The following is a description of a gene set: Any process that stops, prevents, or reduces the frequency, rate or extent of chemical reactions and pathways involving a protein. species: Homo sapiens Human Gene Set: GOBP_NEGATIVE_REGULATION_OF_PROTEIN_METABOLIC_PROCESS, and this is the list of marker genes: VBP1 (NCBI Gene Id 7411), MIR132, C9orf72, SIRT1, TP53, PRKCG, PRKAA2, MIR299, PBK, MAGEA3, TM4SF20, PAQR3, ATG14, GTPBP4, F8A1, STYX, MIR146A, UCHL5 (ubiquitin C-terminal hydrolase L5), MIR499A, PTPN3, AATF, EIF4A3, TMEM98, MARCHF7, DTX3L, AXIN1, MIR103A1, WTIP, JAK3, MAP1A, MAPK8IP1, PTPRJ, FGA (NCBI Gene Id 2243), OGT, PRR5L, MIR133B (NCBI Gene Id 442890), MIR106B, SERPINB13, CLN8, SQSTM1, SPON1, TIMP1, APCS (amyloid P component, serum), PSME3IP1, CDKN2A, MIR24-1, ITGAV, SOCS4, ZNF540, PFDN4, MAP3K20, CDK5RAP1, TREM2, MYCBP2, VPS35, RTN2, INSM1, MIR1271, CAMLG, CSTA, INHBB, MIR361, RNF139, ARRB1, PRNP, LAPTM4B, MIR346, MDM2, MIR214, ADIPOQ, DEPTOR, SERPINB3, SHMT1, MIR135B, GZMB, FETUB, IVNS1ABP, CTNNB1, HDAC6, NELL1, DCUN1D3, EIF4EBP3, INPP5F, SNX12, SAMD4A, MIR339, QKI, VPS25, ZC3H12A, EIF2AK3, CDYL, IBTK, MIR181C, MAD2L1, MIR1-1, MIR96, TYMS (thymidylate synthetase), APOD, TIMP4, ROCK1, GABARAPL2, AJUBA, YBX1, GSKIP, RPL11, XRN1, MAGEA2B, MIR141, SMAD3, PML, EIF4G1, DBNDD2, PSEN1, MIR874, AZIN1, ZFYVE28, SORL1, PTPRC, KNG1, MIR212, CAPRIN1, PHF20L1, ANG, RBM4, MTM1, EIF4EBP2, TRIM71, CYFIP1, SUFU, EGFR, MARCHF6-DT, RPS7, EFNA1, INS, RYBP, SERPINB8, PURA, GRIN2C, PARP14, MIR152, IGF1, NANOS2, ACOT8, TAF9, BTG2, SERPINE2, SAMD4B, MIR378A, HHEX, TTC36, TFAP4, TRIM40 (tripartite motif containing 40), SF3B3, SERPINB9, NANOS1, SRCIN1, BEX3, MEN1, GGA3, PAK2, GPRC5A, PTK6, SNX3, RASSF2, ATP13A2, PTPN2, FBXO5, ITGB1BP1, RELA, HMG20A, SH3RF2, SERPINE1, PTEN, APC, SERPINB12, PRKCA, MIR455, UFL1, LRIG2, RTN3, MIR100, MIR17, BEX4, ZAR1, WAC, BACE2, GBA1, EDNRB, YWHAG, EIF2AK4, STK38, ILF3, MIR200C, TSPO, F2, BAG5, TRIM27, FHIT, SNX6, MIR28, DNAJC3, CST4, IGF2BP3, VPS28, WFS1, CCAR2, MIR106A, ECM1, MIR365A, HSP90AB1, RGP1, ADARB1, PIN1, LYN, WT1, SENP2, PLAU, DEDD, SFRP2, CRB2, SOCS5, MIR26B, EIF4ENIF1, MIR503, MIR15B, ZFP36, PHB1, U2AF2, RIDA, MIR147A, PRKCE, GIPC1, SIRT4, FKBP8, PPP1R15B, MIR644A, ZNF598 (zinc finger protein 598, E3 ubiquitin ligase), CDKN1A, CDK5 (cyclin dependent kinase 5), MIR31, TRIM21, USP4, NOP53, USP17L2, SNCA, PSMF1, USP9X, MIR298, NMNAT2, N4BP1, IL1R2, UBE2B, EPPIN, CNOT1, DDX3X, SLIT2, MIR29A, GIGYF2, GAPDH, SERPINF2, MIR448, SPOCK3, DMTN, RGS2 (NCBI Gene Id 5997), RTN1, RPL23, RBM24, SVBP, PURB, CRTAP, CNOT10, RPS3, UNK, MRPL13, HMG20B, NQO1, DAPK1, MIR15A, NR1H3, MIR148A, WARS1, PPIA, IL10, CELF1, F8A3, HABP4, ITM2A, RPL5, ALKBH3, PINX1, LDLR, MIR659, WNT1, MIR134, NCL (NCBI Gene Id 4691), FLOT2, PFDN1, MIR520E, SIRT2, ACP4, CD84, GPS2, IRAK3, FBLN1, DAPK3, CNOT9, NLRP7, CNKSR3, PKIA (cAMP-dependent protein kinase inhibitor alpha), MAGEA2, GLG1, MINAR1, SHFL, PTX3, GRB7, AKT1S1, MIR10B, MIR29B1, PANO1, PDCL3, UBXN1 (NCBI Gene Id 92151), GADD45A, AIDA, TLK2, MIR153-1, NOS2, ATRAID, MGAT4D, CD300A, GNL3L, HFE, CEP43, EIF2S1, MIR19B1, MIRLET7A1, TNRC6C, PPM1E, MIR181A2, RECK (reversion inducing cysteine rich protein with kazal motifs), MIR128-1, MIR98, LILRB2, TAF1, TIMP3, MIR520C, SVIP, MIR520B, SNRNP70, SENP1, SYNCRIP, USP5, CYP51A1, CSNK2A1, DNAJB2, MIR483, HIPK3, DUSP7, MIR208A, GAS1, THY1, IREB2, PUS7, CAPRIN2, ADAR, PARD3, PABPN1L, MIR181B1, CPEB1, NPPA, RGS14, USP8, HSPA1B, EDN1 (endothelin 1), LIN28A, USP38, MIR182, LSM14A, FLNA, PRKDC, EIF4E, TIA1, MIR101-1, DNAJC1, IGFBP3, MIR939, CEP85, MIR148B, FRY, PRMT3, GCLC, IGFBP5, MIR210, TAF7, CDKN1B, HHATL, PTPN22, DBI, PATL2, SCRIB, TNFAIP3, USP7, CALR, INPP5E, HDAC8, MIR92A1, IGF2BP2, DUSP1, SPRY2, MIR877, PDCD4, MIR145, MIR20A, DEFB114, PLAA, SRP9, SGTA, RTN4, CHRNA7 (cholinergic receptor nicotinic alpha 7 subunit), AGAP2, COPS9, CR1, MGAT3, CADM4, FXR1, SMARCC1, LRRK2, WNK1, MVP, TARDBP, NLRP2B, MIR21, TRIM39, P3H1, DHX36, RIC1, ARHGAP5-AS1, CHMP6, MIR27A, MIR345, UFSP2, CAV1 (NCBI Gene Id 857), MIR125A, MIR186, DHFRP1, PFDN6, VTN, CIRBP, MIR125B1, CHP1, PARK7, UBXN2A, TARBP2 (NCBI Gene Id 6895), MALSU1, MIR126, OTUD6B, ITM2B, RARA, F8A2, LIMD1, MIR221, CSNK2A2, TERF2IP, CORO1C, FLCN (NCBI Gene Id 201163), PCIF1, IGF2BP1, PAIP2B, ZAR1L, SFN, MDM4 (MDM4 regulator of p53, NCBI Gene Id 4194), MAD2L2, SERPINB1, AGO2, TMEM132A, TNRC6A, THBS1 (thrombospondin 1), DAB2IP, MIR200B, QRICH2, RB1, MIR379, ANXA2, SHH, NT5DC2, SPOPL, ACO1, HIPK2, RACK1, BAG6, FMR1, MIR144, NTRK2, MIF, ABL1, MIR323A, PRKAA1, CPEB4, PRKCH, MIRLET7I, MIR6086, EPHA4, MIR29C, PER2, RPL13A, CEACAM1, SPINK5, LAMP3 (NCBI Gene Id 27074), CEP63, HSPA1A, PFDN2, OPHN1, IFRD2, MIR16-1, ADGRB1, MIR27B, MIR204, HEG1, HSPG2, NANOS3, ITGB3, IDE, MIR495, NPM1, PFDN5, TPPP, ARRB2, MIR138-1, SPOCK2, DHFR, TNRC6B, LATS1, NXN, ABCA7, AZIN2, CPEB3, DDRGK1, NIBAN1, NR1H2, SAMSN1, LATS2, RASIP1, TRAF3IP1, HAP1, SLC2A10, CACTIN, SMAD4, GRIN2A, USP26, KLF15 (KLF transcription factor 15), CIB1, MIR181D, EIF4EBP1, HMGCR, SIRT7, AGO1, CDK5RAP3, EIF6, PTPN1, MIR205, ZBED3, ISG15, BEX2, USP44, EIF2AK2, EPRS1, PARP16, CSTB, EIF3H, ALAD, CELF4, DAP, USP25, MIR9-1, CHAC1, AQP11, TPR, SERPINB4, ENC1, KLHL40, USP14, PRG3, ITM2C, CTSA, DDX6, CLU, AKT1, FMN2, SERBP1, DNAJA1, MIR218-1, CPEB2, AGO3, PTPN13, CDKN1C, FURIN (furin, paired basic amino acid cleaving enzyme), ATG5, INCA1, DAPL1 (NCBI Gene Id 92196), CST3, PRMT6, RILP, TOB1, SFRP1, FYN, PYCARD, PARP10, KLHL31, MACROH2A1, BAG2, IAPP, TSG101, BEX1 (NCBI Gene Id 55859), EIF4E2, ZGPAT, MIR590, PAIP2, PLAT, BIN1, SMO, AGO4, CTSZ, MAPT, PIBF1, CSNK2B, ATF4, ERRFI1, LARP1, EIF2AK1, C8orf88, SESN2, AGT, MIR107, CEP78, BANK1, CRYAB, MIR199A1, FSCB, APOE, CRY1, PIAS3, TIMP2, FXYD1, CAPN3, RTRAF, TRIM44, EIF3E, CLN3